The following is a description of a gene set: Any process that modulates the frequency, rate or extent of post-translational protein modification. species: Homo sapiens Human Gene Set: GOBP_REGULATION_OF_POST_TRANSLATIONAL_PROTEIN_MODIFICATION, and this is the list of marker genes: COPS2, CHFR, AMER1, COPS7A, HAMP, DDX3X, UBE2V1, PIAS3, WBP1L, NOP53, MTBP, CRY1, NHLRC1, SIAH2, BAG2, FZR1, ARRDC3, AXIN1 (axin 1), RPS7, U2AF2 (NCBI Gene Id 11338), SPSB4, HSPBP1, HSPA5, RPL11, RNF180, NXN, CBLB, PRKCE, CRTAP, ITCH, PTTG1IP, SIRT7, RIPK2, MAPK9, PINX1, MALT1, MAD2L2, TBC1D7, FBXO5, TGFBR1, FANCM, LRRK2, SKP1 (NCBI Gene Id 6500), PLAA, PSMD10, IVNS1ABP, ANGPT1, HSP90AA1, PEF1, SENP2, GNL3L, FANCI, TAF1, OTUD4, PTPN22, COMMD1, ARRDC4, COPS9, FBXO2, MARCHF7, DNAJB2, FAM107A, UBQLN1, ADGRB1, AKT1, DNAJA3, TANK, FOXF2, ISG15, UBA2, EPM2A, TICAM1, COPS4, ARRB2, ARNT, TRIM44, BMI1, COPS6, FSCB, ABL1, UBE2S, RPL5, UBE2C (ubiquitin conjugating enzyme E2 C), RBX1, PAXIP1, HERPUD1, STUB1, USP4, GNL3, PRKCG, SVBP (small vasohibin binding protein), COPS8, MYCBP2, PABPN1L, BIRC2, SPRY2, CEP78, MINAR1, ZC3H12A, AIMP2, BTRC, NSMCE3, PRMT3, RNF111, COPS5, SPOPL, TCF25, SQSTM1, PELI1, MARCHF6-DT, HUWE1, TRAF6, GPS1, UBE2D1, BAG5, DCUN1D1, HDAC4, UBXN1, HMG20A, KDM1A, PPIA, SASH1, HDAC8, HIF1A (hypoxia inducible factor 1 subunit alpha, NCBI Gene Id 3091), GCLC, MTA1, MAGEA2B, UBE3A (NCBI Gene Id 7337), GSK3A, CAV1, UBE2N, PRICKLE1, RPL23, BIRC3, GSK3B, CENPS, RPS2, FYN, SPRTN, UBE2V2, BIRC7 (baculoviral IAP repeat containing 7), DTX3L, COPS3, WFS1, TNFAIP3, CENPX (NCBI Gene Id 6800), TOLLIP, PLK1, BEX3, UBB, NGF, RELA, INAVA, PHF23, DERL1, WNK1, TTC36, SH3RF2, VCP, LAPTM5, NOD2, CUL3, DCUN1D5, CTNNB1, TRIM21, EGR1, PPIB, CDK5, MAGEC2, PDCD6, FBXW7, DCUN1D2, P3H1, NPM1, PARK7, FBXO4, CEP63, RASD2, DCUN1D4, UFL1, DNAJA1, NDFIP2, BEX2, COPS7B, PER2, FLCN, UBE2L3, PINK1, HSPA1B, PIAS1, TSPO, CDC14B, TNIP1, GPS2, CDKN2A, MUL1, UBXN2A, PRKN, WASHC1, GABARAP, DAXX, RPS3, ATG5, CHP1, CAPN3, MAGEA2, MIR138-1, GTPBP4, SPHK1 (NCBI Gene Id 8877), NDFIP1, CAMLG (calcium modulating ligand), WDR48, ABCA2, BCL10, DCUN1D3, OGT, SAE1 (SUMO1 activating enzyme subunit 1), EPAS1, BEX1, RWDD3, BIRC8, XIAP, HSPA1A, ARRB1, TSPYL5, SKP2, RCHY1, CDC20, RASSF1, HDAC3, VPS28, KLHL40, CDK5RAP3, MAD2L1, MIR101-1, TRIB3, N4BP1, HMG20B, PARP10, NMI, RASSF5, HSP90AB1, BEX4, USP44, PIAS4, UBE2B, SEPTIN4, FBXO33